Given this list of marker genes Impdh1, Gmpr2, Ampd1, Adss1, Adss2, Adsl, Aprt (NCBI Gene Id 97468), Adk, Ampd2, Gmps, Ampd3, Hprt1 (NCBI Gene Id 97612), Ada, Gmpr, Pnp, Impdh2, here is a description of the gene set: Any process which produces a purine ribonucleotide from derivatives of it, without de novo synthesis. studied in species Mus musculus Mouse Gene Set: GOBP_PURINE_RIBONUCLEOTIDE_SALVAGE